Given this list of marker genes Kit (KIT proto-oncogene receptor tyrosine kinase), Ptpn6, Lyn, Lck, Sh2b3, Yes1, Grb2, Cbl, Fyn, Sos1, Sh2b2 (SH2B adaptor protein 2), Kitl, Src, here is a description of the gene set: Regulation of KIT signaling studied in species Mus musculus Mouse Gene Set: REACTOME_REGULATION_OF_KIT_SIGNALING